The following is a description of a gene set: Any deviation from the normal level of growth hormone (GH) in the blood circulation. GH or somatotropin is a peptide hormone that stimulates growth, cell reproduction, and cell regeneration. Its secretion from the pituitary is regulated by the neurosecretory nuclei of the hypothalamus, which can release Growth hormone-releasing hormone (GHRH or somatocrinin) and Growth hormone-inhibiting hormone (GHIH or somatostatin) into the hypophyseal portal venous blood surrounding the pituitary. GH is secreted in a pulsatile manner, which is one of the reasons why an isolated measurement of its blood concentration is not meaningful. species: Homo sapiens Human Gene Set: HP_ABNORMAL_GROWTH_HORMONE_LEVEL Abnormal growth hormone level, and this is the list of marker genes: ROBO1, KMT2D, TMEM67, OTX2, NRAS, GH1, CDKN1A, PDE11A, GNAQ, MAP2K1, MANF, CDH23, CDKN1B, CDKN2B, MARS2, HPGD, PRKAR1A, CDKN2C, PNPLA6, MEN1, KCNJ11 (potassium inwardly rectifying channel subfamily J member 11), IGF1, FANCI, RNU4-2, DNA2, CREBBP (CREB binding protein), BRAF, GPR101, PROP1, RAP1B, GNAS, KDM6A, SLCO2A1, DSG1, PMM2, AIP, POU1F1, MPV17